Given this list of marker genes Mxd1, Jund, Dusp1, Jun, Lyst, Mark3, Sik2, Trio, Tomm7 (NCBI Gene Id 66169), Mfge8, Synpo2, Fos, Hspa1b, Insm1, Icosl, Hspa1a, Slc6a6, H2-M2, Fosb, Mt1, Rptor, Rgs1, Sesn3, Sec11c, Mx1, here is a description of the gene set: Genes negatively differentially expressed in cell type: MigDC (migratory dendritic cell) upon treatment with cytokine: IL-3 in mouse lymph nodes in vivo. from publication Cui A, Huang T, Li S, Ma A, Pérez JL, Sander C, Keskin DB, Wu CJ, Fraenkel E, Hacohen N (PMID 38057668) Mouse Gene Set: CUI_MIGDC_IL3_RESPONSE_DN Cytokines mediate cell-cell communication in the immune system and represent important therapeutic targets. A myriad of studies have highlighted their central role in immune function, yet we lack a global view of the cellular responses of each immune cell type to each cytokine. To address this gap, the authors created the Immune Dictionary, a compendium of single-cell transcriptomic profiles of more than 17 immune cell types in response to each of 86 cytokines (>1,400 cytokine-cell type combinations) in mouse lymph nodes in vivo. A cytokine-centric view of the dictionary revealed that most cytokines induce highly cell-type-specific responses. For example, the inflammatory cytokine interleukin-1β induces distinct gene programmes in almost every cell type. A cell-type-centric view of the dictionary identified more than 66 cytokine-driven cellular polarization states across immune cell types, including previously uncharacterized states such as an interleukin-18-induced polyfunctional natural killer cell state. studied in species Mus musculus